Given this list of marker genes POLR2G, TTC17 (NCBI Gene Id 55761), FBXL5, CALCOCO1, G3BP1, AGAP1 (ArfGAP with GTPase domain, ankyrin repeat and PH domain 1), NOVA1, LAT, FTHL17, SIN3A, CAVIN1, SGIP1, MAP3K8, SLC25A14, ANKLE2, INO80D, ERRFI1, TMEM74, PPP1R11, CEP170B, HHAT, PRC1 (NCBI Gene Id 9055), PURG, KLF7, MYT1, PSMD9, DCAF7, CAT (NCBI Gene Id 847), CALHM5, VPS13D, ZFYVE1, ITGB3, BCORL1, PHOX2B, MGAT5B, CMTM6, SLFN5 (NCBI Gene Id 162394), TOX, KCNK5, PRKAR2A, GPATCH2L, ASPH, ANKRD46, SPRY4, SLC12A6, PKN2, LRRC8E, TMEM237, ZC4H2, RGS5, TRAF6, PIAS1, ZBTB22, MED20, ZNF195, CPLX4, MAT2A, TTC31, SHCBP1, SET, MPPE1, PIP4K2B, NPTN, MYO6, ELAC1, PRICKLE2, SEH1L, VAPB, ROR1, TMEM185B, PHKB, TNRC6A, SLC3A1, MOCS1, TMEM132D, ETV5, DCUN1D2, BMPR1A, IRAK1 (interleukin 1 receptor associated kinase 1), RFXAP, PNPLA4, CXXC4, UMPS, TRMT9B, ATP23, BAG1, RCAN3, here is a description of the gene set: species: Homo sapiens Genes predicted to be targets of miRBase v22 microRNA hsa-miR-589-5p in miRDB v6.0 with MirTarget v4 prediction scores > 80 (high confidence targets). from publication Chen Y, Wang X (PMID 31504780) Human Gene Set: MIR589_5P